Given this list of marker genes PAX5, FAM219A, RECK, TSPEAR, YTHDC1, GAREM2, KCNMB2, here is a description of the gene set: species: Homo sapiens from publication Chen Y, Wang X (PMID 31504780) Genes predicted to be targets of miRBase v22 microRNA hsa-miR-4730 in miRDB v6.0 with MirTarget v4 prediction scores > 80 (high confidence targets). Human Gene Set: MIR4730